Given this list of marker genes ZNF675, TNFRSF11B, EEIG1, TMEM178A, FSHR, IFNG, MITF, BGLAP, CEBPB, MAFB, GPR137B, CALCA, FSHB, IL20, TM4SF19, PPARGC1B, IL17A, IL4 (NCBI Gene Id 3565), PIAS3, CCR1, TOB2, FSTL3, MTOR, NF1, TLR4, NOTCH2, TNF, CSF1, CCL3, PRXL2A, GPR137, INPP5D, KLF10, CAMK4, LRRC17, GPR55, FBXW7, RPTOR, CTNNB1, IAPP, IL23A, TNFRSF11A, LILRB3, CREB1, TCTA, TNFSF11, LILRB1, TLR3, ERFE, TRAF6, FBN1, IL12B, CLDN18, SLC9B2, FOS, POU4F2, PIK3R1 (NCBI Gene Id 5295), PPP3CA, UBASH3B, OCSTAMP, RASSF2, LTF, LILRB4, TMEM64, TREM2, CARTPT, SFRP1, GPR68, POU4F1, TYROBP, TFE3, TNFAIP6, IL23R, NEDD9, here is a description of the gene set: Any process that modulates the frequency, rate or extent of osteoclast differentiation. Human Gene Set: GOBP_REGULATION_OF_OSTEOCLAST_DIFFERENTIATION studied in species Homo sapiens